The following is a description of a gene set: studied in species Mus musculus Mouse Gene Set: GOBP_IMPORT_INTO_CELL The directed movement of some substance from outside of a cell into a cell. This may occur via transport across the plasma membrane or via endocytosis., and this is the list of marker genes: Gata2, Ackr3, Calcrl, Slc39a11 (solute carrier family 39 (metal ion transporter), member 11), Cltrn, Itga4, Pycard, Gas6, Arl8b, Pla2g5, Fpr-rs7, Wdr72, Apoa1, Klrh1, Mertk, Kcnq3, Cdc42 (cell division cycle 42), Ppt1, Ighe, Slc30a8, Slc9a3, Kcnk9 (potassium channel, subfamily K, member 9), Ppp3cc, Cd300lf, Rab27a, Dnm1l, Ldlrad3, Cxcr1, Actb, Abr, Anxa2 (annexin A2), Ntf3, Ush1g, Kcnj14, Slco1b2, Acsl5, Cln8, Adm, Rap1gap, Timd5, Atg7, Clint1, Cblb, Slc6a5, Tnf, Atp9a, Calm3, Slc6a6, Rit2, Mrc2, Prkcd, Wasl, Slc2a5 (NCBI Gene Id 56485), Cebpe, Csnk1d (casein kinase 1, delta), Pot1b, Bcl2l1, Tgfbr2, Ptk2, Slc12a1, Ccl19, Timd2, Ehd1, Pros1, Trip10, Dlg1, Aplnr, Kcnh2, Btbd8, Myo19, Arc, Neurl1b, Itgb3, Slc22a4, Scarb2, Lrp1, Lman2, Tsc2, Ncl, Slc17a8, Apoc3, Asgr1, Rab14, Prkcg (protein kinase C, gamma), Vtn, Ighg1, Sftpa1, Egf, Cd209a, Slc2a10, Hpse, Rab5a, Actn4, Pip5k1c, Slc16a2, Rala (NCBI Gene Id 80577), Abl2, Slc30a5, Arrb2, Slc38a5, Btk, Usp20, Kcnq1 (NCBI Gene Id 547397), Scarb1, Fnbp1l (NCBI Gene Id 99918), Mtmr9, Slc9a4, Csk, Sh3glb2, Mex3b, Gak, Arap1, Adrb2 (NCBI Gene Id 269028), Trpm2, Pstpip1, Slc2a4, Snph, Acsl1 (acyl-CoA synthetase long-chain family member 1), Eprs1, Pik3ca, Kcne2, Timd4, Lrp10, Bicd1, Myo1b, Rnf216, Slc6a20b, Ulk1, Knl1, Acsl6, Ldlrap1, Rps6kb1, Epn1, Trpv2, Cdc42se2, Cacna1e, Cd209d, Lilrb4b, Scamp5, Sdcbp, Pard3, Lpar1, Canx, Nat8l (NCBI Gene Id 68762), Lbp, Sftpd, Lrrtm1, Colec10, Chrna7, Ly75, Trpm1, Pld2 (NCBI Gene Id 18806), Slc22a3, Cxadr, Ceacam1, Amph, Rab7b, Apoa2, Slc6a14, Trpv6, Itgav, Rab17, Tyro3, Ano6, Ifng, Slc6a3, Il4, Lmbr1l, Drd3, Cxcl16, Il10ra, Ube3a, Ifitm3, Syp, Bin2, Arhgap12, Myo7b, Grb2, Dnm2, Wnt5a, Nckipsd, Colec12, Rab20, Clec7a, Ctbp1, Snap91 (NCBI Gene Id 20616), Ap3b2, Lrp5, Treml4, Ahi1, Snca, Elmo1, Myo5b, Slc1a7, Cdk5, Rab22a, Eef2k, Nr1h3, Lmbrd1, Syt11, Kcnq2, Synrg (synergin, gamma), Hcn2, Mff (mitochondrial fission factor), Cd302, Pld4, Vamp8, Slc43a2, Cd9, Park7, Necap1, Rab39, Wasf2, Fcgr1, Ap2s1, Gdnf, Cd209b, Ahsg, Rab34, Stra6, Slc39a12 (NCBI Gene Id 99291), Mesd, Cd47, Ighg2b, Mbl2, Nedd4, Eps15, Myh9, Sncg, Slc18b1, Arf6, Pten, Myo1c (NCBI Gene Id 97728), Agt, Slc12a8, Ramp2, Tgm2, Rnasek, Csnk1g2, Slc38a4, Rab1a, Hap1, Slc27a6, Tulp1, Rgs2, Marco, Bltp1, Kcnj2, Dkk1, Ccr2, Gsg1l, Rufy1, Fyn, Lrrc8e, Flot1, Cd81, Kcnj9, Numb, Siglech, Itgal (integrin alpha L), Slc46a2, Rin3, Pear1 (platelet endothelial aggregation receptor 1), Ceacam2, Gsn, Lrrc8d, Stab2, Rhoq, Eea1, Reps1 (RalBP1 associated Eps domain containing protein), Myo1h, Csnk1e, Cav2, Ramp1, Msr1, Kcnj15, Cdh13, Appl1, Colec11, Acsl3 (acyl-CoA synthetase long-chain family member 3), Becn1, Rac1, Itsn1, Myo1d, Kcnj13, Ncf4, Pllp, Calr (NCBI Gene Id 12317), Slc29a2, Slc9a1, Ptprc, Slc38a2, Lrp4, Heatr5b, Ankfy1, Ralb, Arf1, Mx2, Rbp4, Ap3d1, Tspo2, Coro1c, Aqp8 (aquaporin 8), Slc27a5, Fcgr4 (NCBI Gene Id 320130), Ptger3, Atp6v1h, Prkca (protein kinase C, alpha), Xkr8, Usp46, Clta, Prkn, Lepr, Scyl2, Prnp, Ubqln2, Ap2a1, Nfix, Tm9sf4, Trf, Efnb2, Nod2, Hip1, Opa1, Rab21, Arhgap25, Gas7, Arrb1, Ckap5, Angpt1, Dmbt1, Slc12a6, Josd1, Atg3, Insr (insulin receptor), Mdm2, Rin1, Rara, Slc5a2, Abca1, Heatr5a, Ophn1, Cubn, Pacsin3, Slc7a2, Hck, Lrp2, Rab4a, Ank3, Fpr2, Sirpa, Ncdn, Scara5 (scavenger receptor class A, member 5), Kcnj4, Slc22a2, Bmp2k, Diaph1, Gpm6b, Nos1, Jmjd6, Drd2, Slc7a5, Cttn, Bin1, Lgals3, Hras, Hamp, Rab7, Cacna1b, Ppp3cb (NCBI Gene Id 66215), Arfgap3, Sh3bp1, Abcc1, Esyt2, Epn2, Necab2, Anxa1, Clec4f (C-type lectin domain family 4, member f), Tlr4, Npc1, Slc7a3, Slc39a14, Arg2, Agtr1a, Kcnj5, Thbs1, Fnbp1, Septin2, Grm6, C4bp (complement component 4 binding protein), Elmo3, Rabgef1, Ezr, Sirpb1a, Tfrc, Pik3cg, Ghr, Serpine1, Lrp6, Snx9, Sh3gl3, Scamp1, Nlgn1, Coro1a, C3, Xkr4, Elmo2, Mapk3, Ppp3r2, Slc11a1, Myo1g, Caly, Lyar, Dab2, Myo5c, Dtnbp1, Ehd3, Timd6, Rspo1, Psg22, Sdc1, Slc17a6, Ldlr, Ccr7, Dnajc13, Tspan7, Bin3, Steap2, Slc15a2, App, Slc9c1, Slc47a1, Kcnj11, Nherf1, Itgb2, Vegfa, Pik3c2a, Slc8a2, Tsg101, Cln3, Trpv3, Mlc1, Drd4, Il2rg, Gria2, Hip1r, Cav3, Ap3s1, Ache, Cav1, Abca13, Rabgap1l, Plscr1, Myd88, Hmmr, Slc12a4, Clu, Dysf, Reps2, Slc5a1, Havcr1, Ptpn1, Synj2, Lilrb4a, Xkr6, Adrb1, Pik3cb, Slc9b2, Slc12a7, Rabep1, Cdc42se1, Apoc2, Mtmr2, Tamalin, Snx10, Apln, Ehd4, Dgkq, Actg1, Clcn3, Tfr2, Scn5a, Itsn2, Lrrc8c, Snx3, Il15, Cacna1c, Mfge8, Pik3c3 (phosphatidylinositol 3-kinase catalytic subunit type 3), Smpd1, Syngr3, Itgam, Wdr54, Kcnj10, Dpysl2, Trem2, Gapvd1, Slc1a6, Slc6a2, Neu3, Ptpn5, Grk2, Rnf220, Elane, Atg5, Tpcn2, Slc1a4, Myo18a, Ap2b1, Atad1, Pick1, Apoe, Adipoq, Gulp1, Cryba1, Cd36, Myo1f, Fxyd2 (FXYD domain-containing ion transport regulator 2), Trpm4, Lrrk2, Atp8a1, Lrp8 (NCBI Gene Id 16975), Arl6ip5, Kcnj3, Slitrk1, Sh3gl2, Ap3m2, Inppl1, Slc1a5, Akap5, Calm2, Fgr, Cnga3, Dennd1a (NCBI Gene Id 338506), Myo1e, Fpr-rs4, Dcx, Ccdc32, Lrp12, Sh3kbp1, Sphk1, Sag, Lrsam1, Ins2, P2rx1, Enthd1, Cd14, Spon2, Axl, Slc27a4, Itgb1, Myo1a, Spx, Mib1, Slc6a4, Slc12a5, Sfrp4, Ralbp1, Tub, Tbc1d24, Fcer1g, Slc18a2, Atp1a3, Hmgb1, Nalf1, Smap1, Arhgap21, Add1, Gria1, Syt17, Snx18, Slc5a6, Anxa3 (annexin A3), Slc19a1, Dnajc6, Cd151, Lrp1b, Ehbp1, Fcnb, Xkr7 (NCBI Gene Id 228787), Cacna1d, Pip4p2, Clcn2, Plcg2, Ppp3r1, Apoc2l, Grn, Ighm, Slc15a3, Rab11fip2, Prtn3, Hgs, Scrib, Tafa4, Arg1, Gpr107, Kcnj12, Cd300a, Atp5f1b, Slc1a2, Fcho2, Srpx, Trex1, Rab3b, Ager, Snx17, Appl2, Pawr, Pikfyve, Hpca, Slc9a9, Abca2, Tnk2, Cfp, Rubcn, Entrep1, Aif1, Slc9a6, Megf10, Arl6ip1, Snx12, Sh3bp4, Csnk1g1 (NCBI Gene Id 71616), Slc43a1, Cnn2, Kcnn4, Dnm1, Rin2, Trpv5, Slc39a4, Washc5, Sele, Slc6a7, Slc3a2, Mapk1, Plk2, Nrg1, Pacsin1, Ndp, Snx33, Slc39a5 (solute carrier family 39 (metal ion transporter), member 5), Gpc3, Adgrb1, Ace2, Unc13d, Rab5b, Micall1, Atp1a1, Hspg2, Fev (NCBI Gene Id 260298), Dennd1b, Capn2, Sort1, Dll1, Slc24a4, Abca7, Vamp4, Rab11fip5, Pla2r1, Camk1d (calcium/calmodulin-dependent protein kinase ID), Wnk4, Rab27b, Cd44, C9orf72, Sgip1, Fcer2a, Spry2, Stra6l, Wnk1, Spg11, Fcho1, Lrrc8b, Fcgr2b, Cap1, Fkbp15, Per2, Ston2, Bcr, Aak1, B2m, Slc6a11, Iqsec1, Tmem175, Carmil1, Rock1, Prom2, Ccl2, Abcc9, Vamp2, Grk4, Lyve1, Slc6a1, Dock1, Nlgn3, Fmr1, Icam5, Mkln1, Apoc1, Lrrc8a, Sncb, Atp4b, Cd24a, Akt1, Marchf3, Fcgr3, Dppa1, Atp1a2, Lrp11, Irs2, Nckap1l, Myo5a, Cd22, Mbl1 (mannose-binding lectin (protein A) 1), Src, P2rx5, Alox15, Rhou, Psen1, Clip3, Neurl3, Rhov, Inpp5f, Akt2, Slc28a1, Ntsr1, Ank2, Snx5, Plxnb2, Slc36a2, Nostrin, Letmd1, Lrpap1 (low density lipoprotein receptor-related protein associated protein 1, NCBI Gene Id 97224), Susd4, Eif2ak1, Clcn5, Mapkapk2, Slc12a3, F2rl1, Mrc1, Myo15a, Lipa, Fchsd2, AU040320, Cltc, Ap3m1, Myo6, Grm1, Kcnk5, Ramp3, Wasf1, Vldlr, Slc34a1, Hfe (NCBI Gene Id 15216), Trpv1, Slc48a1 (solute carrier family 48 (heme transporter), member 1), Apela, Kcnc3, Il2rb, Clec9a, Cd177, Rhoj, Stx1a, Slc6a13, Pecam1, Wnk2, Slc38a1, Atp1b1, Slc8a3, Rap1a, Mapkapk3, Cd63, Siglecf, Slc6a9, Ap2a2, Abl1, Arfgap1, Sorl1, Cxcr2, Tbc1d2b, Asic5, Mtmr6, Rabep2, Slc15a4, Slc27a1, Grem1, Synj1, Slc2a1, Nsf, Dennd1c, Shoc2, Dgkd, Nos2, Rab5c, Grk3, Cltb, Slc39a10, Trpv4, Slc1a3, Nr1h2, Pacsin2 (NCBI Gene Id 23970), P2ry6, Nedd4l, Lep, Slc11a2, Cacna1f, Atxn2, Lrrtm2, Slc31a1, Lyst, Kif3a, Sirt2, Il15ra, Slc39a8, H1f1, Ptprj (NCBI Gene Id 98976), Ankrd13a, Tmem108, Csnk1g3, Egfr, Slc17a7, Pcsk9, Atp12a, Cyba, Alms1, Necap2, Kcnj8, Ankrd13b, Btbd9, Hcn4, Nme1, Slc9a5, Atp4a, Fcmr, Hspa8, Asgr2, Arhgap27, Slamf1, Tgfb1, Tbc1d5, Scnn1a, Slc29a1, Amn, Scnn1b, Stap1, Mst1r (NCBI Gene Id 235603), Lcn2, Eps15l1, Magi2, Cacna1s, Hamp2, Dnm3, Slc12a2, Arpc3, Kcnj6, Vav1, Rab31, Sod1, Wnk3, Tusc2, Ins1, Atp9b, Ap2m1, Kcnj1, Ticam2, Syt4, Anxa11, Ms4a1, Ccl21a, Pparg, Sh3gl1, Tyrobp, Dbnl, Fabp3, Zp3r, Atp1b3, Kcnj16, Epha3, Syt7, Ap3s2, Cd2ap, Arhgef11 (Rho guanine nucleotide exchange factor 11), Slc39a6, Kcnd3, Slc18a3, Ston1, Slc9a7, Rack1, Slc38a3, Rgs4, Rinl, Slc6a20a, Rapgef1, Marchf2, Ankrd13d, Ncf2 (NCBI Gene Id 17970), Epn3, Eqtn, Slc46a1, Aplp1, Syk, Stx1b, Creg1, Slc27a2, Itga2, Fpr-rs6, Usp33, Slc9a2, Irf8, Arr3, Itch, Calm1, Rab11b, Myo7a, Fpr-rs3, Napb, Cbll1, Slc29a4, Ppp3ca, Slc15a1 (solute carrier family 15 (oligopeptide transporter), member 1), Rab4b, Wnt3a, Vac14, Iscu, Slc7a11, Cacna1a, Atp1b2, Slc7a8, Slc24a2, Dlg4, Siglece, Tlr2, Dock2, Shh, Gfap, Slc36a1, Slc18a1, Slc22a1, Hnrnpk, Cbl, 4933434E20Rik, Siglec1, Tor1a, Unc119, Cntn2, Ehd2, Cd209e, Slc7a1, Mctp1, Nalf2, Synj2bp, Ptx3, P2rx7, Picalm, Slc1a1, Slc30a1, Vps28, Scnn1g, Slc8a1, C2, Atp1a4 (ATPase, Na+/K+ transporting, alpha 4 polypeptide), Snx1 (sorting nexin 1)